Given this list of marker genes Gas6, Bglap2, Bglap, F7, F5, Bglap3, Postn, here is a description of the gene set: Any process that results in a change in state or activity of a cell or an organism (in terms of movement, secretion, enzyme production, gene expression, etc.) as a result of a vitamin K stimulus. studied in species Mus musculus Mouse Gene Set: GOBP_RESPONSE_TO_VITAMIN_K